Given this list of marker genes PPIB, FKBP10, MEG3, THRA, CHD4, NOTCH3, MSX2, KDELR2, SP7, PDGFRB, LEMD2, LMNA, PLOD2, FLNA, BCL11B, IFITM5, RTL1, ARID2, TENT5A, CCDC134, WNK1, SCN9A, SH3PXD2B, RETREG1, FBLN5 (NCBI Gene Id 11268), NEK1, ATP7A, LRP5, DLK1, CREB3L1, RUNX2, SEC24D, AFF4, ATP6V0A2, TAPT1, PYCR1, ELN, CRTAP, PAM16, PRKG2, KIF1A, GORAB, HSPG2, ERI1, COL1A2, BMP1, ZMPSTE24, ALDH18A1, AIFM1, GNPNAT1 (NCBI Gene Id 64841), SMO, CTSK, NOTCH2 (notch receptor 2), HPGD, MESD, P4HB, COL1A1, TMEM38B, POGZ, P3H1, SETBP1, NFIX (NCBI Gene Id 4784), here is a description of the gene set: Human Gene Set: HP_WORMIAN_BONES studied in species Homo sapiens Wormian bones The presence of extra bones within a cranial suture. Wormian bones are irregular isolated bones which appear in addition to the usual centers of ossification of the cranium.